Given this list of marker genes SIX3, METTL27, DNAJC30, SEMA3E, LMNA, LIMK1, FGFR1, RFC2 (replication factor C subunit 2), PTCH1, ALX1 (NCBI Gene Id 8092), MTHFR, CHD7, STX1A, GTF2IRD2, BUD23, GTF2I, DYM, NBAS, CLIP2, FIG4, TCOF1, ERI1, TGIF1, FGFR2, TWIST2, NOTCH2, VPS13B, TBL2, BRAF, POLR1B, POLR1C, MAP2K1, POLR3A, ELN, FKBP6, CEP120, BAZ1B, SF3B4, NECTIN1, NCF1, TMEM270, RUNX2, OFD1, COL11A1, KRAS, CNOT1, SF3B2, VPS37D, GLI2, MAP2K2, EDA, VANGL2, POLR1D, GTF2IRD1, SMOC1, EIF4H, PEPD, here is a description of the gene set: Human Gene Set: HP_APLASIA_HYPOPLASIA_OF_FACIAL_BONES studied in species Homo sapiens A developmental defect characterized by absence or underdevelopment of one or more facial bone. Aplasia/Hypoplasia of facial bones